Given this list of marker genes NCAPH, KNL1, TTK, ESPL1, MOS, NCAPH2, MAPK15, M1AP, ZWINT, CHFR, here is a description of the gene set: studied in species Homo sapiens The process in which chromosomes are physically detached from each other during meiosis. Human Gene Set: GOBP_MEIOTIC_CHROMOSOME_SEPARATION